The following is a description of a gene set: studied in species Homo sapiens Lipoxins A4 (LXA4) and B4 (LXB4), structurally characterized from human neutrophils incubated with 15-hydroperoxy-eicosatetraenoic acid (15-HpETE), each contain three hydroxyl moieties and a conjugated tetraene. The third hydroxyl of LXA4 is positioned at C-6, and of LXB4 at C-14. The action of arachidonate 5-lipoxygenase (ALOX5), in concert with an arachidonate 12-lipoxygenase (ALOX12) or arachidonate 15-lipoxygenase (ALOX15) activity, has been shown to produce lipoxins by three distinct pathways. Neutrophil ALOX5 can produce and secrete leukotriene A4 (LTA4) that is taken up by platelets, where it is acted upon by ALOX12 to form lipoxins. Likewise, ALOX15s can generate either 15-hydroperoxy-eicosatetraenoic acid (15-HpETE) or 15-hydro-eicosatetraenoic acid (15-HETE) that can be taken up by monocytes and neutrophils, where highly expressed ALOX5 uses it to generate lipoxins. Finally, aspirin acetylated prostaglandin G/H synthase 2 (PTGS2), rendered unable to synthesize prostaglandins, can act as a 15-lipoxygenase. This leads to the formation of 15R-HETE and culminates in creation of epi-lipoxins, which have altered stereochemistry at the C-15 hydroxyl but similar biological potency. Reactome Pathway: Biosynthesis of Lipoxins (LX) part of: Biosynthesis of specialized proresolving mediators (SPMs), and this is the list of marker genes: ALOX5AP, ALOX5, HPGD, PTGR1, ALOX12, LTC4S